The following is a description of a gene set: Human Gene Set: GOBP_DERMATAN_SULFATE_PROTEOGLYCAN_METABOLIC_PROCESS species: Homo sapiens The chemical reactions and pathways involving dermatan sulfate proteoglycans, which consist of a core protein linked to a dermatan sulfate glycosaminoglycan. The dermatan sulfate chain is composed of the repeating disaccharide unit beta-(1,4)-D-hexuronic acid-beta-(1,3)-N-acetyl-D-galactosamine. The former can be a mixture of sulfated and nonsulfated D-glucuronic and L-iduronic acids, and the latter can be O-sulfated., and this is the list of marker genes: HEXA, IDUA, UST, IDS, CSGALNACT2, HEXB, DSEL, CHST14, B3GALT6, CSGALNACT1, B3GAT3, CHST12, DSE